Given this list of marker genes CYP1A2, GSTM1, UGT2B4, CYP1A1, UGT1A4, CYP46A1 (cytochrome P450 family 46 subfamily A member 1), SULT1C3, ADA, GUK1, VKORC1, AIP, SLCO2B1, CYP3A7, CYP2C8, CYP2U1, NUDT15, ABCC4, CYP2R1, GSTO1, ACAA1, SLC28A3, NOS1, SULT1B1, CYP2D6, CBR1, BCHE, POR, ABCC1, CYP2B6, SULT1A2, ABCB1, AOX1, N6AMT1, SULT1A1, GLYAT, NCEH1, RORC, CYP2C19, FMO1, SULT2A1, S100A12, ACSM1, SLC22A7, CYP26B1, ABCC5, FMO5, GSTA2, CYP4F2, ALDH3A1, CBR3, MIR27B, PRKCE, UGT2B7, HNF4A, UGT2A2, UGT1A1, GSTA1, SLC29A3, SLC22A1, CYP3A5, GSTP1, UGT1A9, AHRR, UGT1A3, CYP26A1, RORA, GSTM4 (glutathione S-transferase mu 4), CYP1B1, UGT1A6 (NCBI Gene Id 54578), SULT1A4, NQO1, GRIN1, SULT1A3, AS3MT, FMO2, ABCC2, ALDH2, UGT1A7, GSTM3, MIR378A, UGT1A10, NAT2 (N-acetyltransferase 2), UGT1A8, CYP2W1 (cytochrome P450 family 2 subfamily W member 1), UGT2A1, GSTA3, SLCO1B1, CES2, RBBP9, UGT2A3, AKR1C1, TPMT, GSTM2, ABHD10, ABCB11, AADAC, CYP2S1, CYP2C9, UGT2B11, GSTO2, CYB5B, SLCO1A2, CRYZ (NCBI Gene Id 1429), LPO, FMO4, CYP2F1, CYP2J2, SLC29A1, CES3, CYP3A4, AHR, ACSL1, CYP2A7, NAT1, UGT2B17, CYP2A6, CYP2E1, AOC2, CMBL, SULT1C4, ACSM2B, CYP2C18, CYP2A13, GSTA4, SMOX, EPHX1, NR1I2, BPHL, CYP4F12, SLCO1B3, SLC28A2, ABCC3 (ATP binding cassette subfamily C member 3), GSTA5, CAD, UGT2B15, here is a description of the gene set: species: Homo sapiens Human Gene Set: GOBP_XENOBIOTIC_METABOLIC_PROCESS The chemical reactions and pathways involving a xenobiotic compound, a compound foreign to the organism exposed to it. It may be synthesized by another organism (like ampicilin) or it can be a synthetic chemical.